The following is a description of a gene set: from publication Querec TD, Akondy RS, Lee EK, Cao W, Nakaya HI, Teuwen D, Pirani A, Gernert K, Deng J, Marzolf B, Kennedy K, Wu H, Bennouna S, Oluoch H, Miller J, Vencio RZ, Mulligan M, Aderem A, Ahmed R, Pulendran B (PMID 19029902) Human Gene Set: QUEREC_MODEL_PBMC_YF_17D_VACCINE_AGE_18_45YO_3DY_PREDICTIVE Genes that are components of a model predictive of response in peripheral blood mononuclear cell 3d vs 0d in adults (18-45) after exposure to YF-17D vaccine, time point 3D. Comment: Suppl Table 4: genes validated by ClaNC as being predictive of CD8+ T cell responses from Fig. 4. studied in species Homo sapiens A major challenge in vaccinology is to prospectively determine vaccine efficacy. Here we have used a systems biology approach to identify early gene 'signatures' that predicted immune responses in humans vaccinated with yellow fever vaccine YF-17D. Vaccination induced genes that regulate virus innate sensing and type I interferon production. Computational analyses identified a gene signature, including complement protein C1qB and eukaryotic translation initiation factor 2 alpha kinase 4-an orchestrator of the integrated stress response-that correlated with and predicted YF-17D CD8(+) T cell responses with up to 90% accuracy in an independent, blinded trial. A distinct signature, including B cell growth factor TNFRS17, predicted the neutralizing antibody response with up to 100% accuracy. These data highlight the utility of systems biology approaches in predicting vaccine efficacy., and this is the list of marker genes: SMARCD3, TUFM, TBC1D7, TMEM176A, CXCR6, SLC16A5, NRGN, SAT2, ATP6V1E1, SLC2A6, GAS2L1, EIF4G3, HTRA4, PRAM1, CD69, FERMT3, HBB, CENPB, BNIP3L, ALDH3B1, NAPRT, GBGT1, FBXO15, STK17A, GAA, BCKDK, CRAT, RAB8B, IMPDH1, TMEM176B (transmembrane protein 176B), ASGR2, ACKR3, CAMKK2, GPR18, C1QB, TNFSF14 (NCBI Gene Id 94566), JUN, TCEAL4, PNPLA6, BIRC3 (baculoviral IAP repeat containing 3), CALR, ZNF606, RGS1 (NCBI Gene Id 5996), ZFP82, ZYX, CTSB, TEP1, ETV3